The following is a description of a gene set: from publication Fu D, Brophy JA, Chan CT, Atmore KA, Begley U, Paules RS, Dedon PC, Begley TJ, Samson LD (PMID 20308323) Human Gene Set: FU_INTERACT_WITH_ALKBH8 Proteins identified by mass spectrometry in complexes containing ALKBH8. tRNA nucleosides are extensively modified to ensure their proper function in translation. However, many of the enzymes responsible for tRNA modifications in mammals await identification. Here, we show that human AlkB homolog 8 (ABH8) catalyzes tRNA methylation to generate 5-methylcarboxymethyl uridine (mcm(5)U) at the wobble position of certain tRNAs, a critical anticodon loop modification linked to DNA damage survival. We find that ABH8 interacts specifically with tRNAs containing mcm(5)U and that purified ABH8 complexes methylate RNA in vitro. Significantly, ABH8 depletion in human cells reduces endogenous levels of mcm(5)U in RNA and increases cellular sensitivity to DNA-damaging agents. Moreover, DNA-damaging agents induce ABH8 expression in an ATM-dependent manner. These results expand the role of mammalian AlkB proteins beyond that of direct DNA repair and support a regulatory mechanism in the DNA damage response pathway involving modulation of tRNA modification. species: Homo sapiens, and this is the list of marker genes: CCT8, ALKBH8 (alkB homolog 8, tRNA methyltransferase), ECSIT, TRMT112 (tRNA methyltransferase activator subunit 11-2), CCT4, CCT3, CCT7, CCT2, CCT6A, HSP90AA1, DBI, CCT5, TCP1